Given this list of marker genes RIPPLY2, DSE, SOX9, ARSL, FLNB, HSPG2, CHST14, GZF1, SLC26A2, here is a description of the gene set: Cervical kyphosis Exaggerated convexity of the cervical vertebral column, causing the cervical spine to bow outwards and take on a rounded appearance. species: Homo sapiens Human Gene Set: HP_CERVICAL_KYPHOSIS